The following is a description of a gene set: Catalysis of the reaction: 3'-phosphoadenosine 5'-phosphosulfate + an alcohol = adenosine 3',5'-bisphosphate + an alkyl sulfate. Mouse Gene Set: GOMF_ALCOHOL_SULFOTRANSFERASE_ACTIVITY studied in species Mus musculus, and this is the list of marker genes: Sult2b1, Sult2a8, Sult2a4, Sult2a6, Sult2a3, Sult2a5, Sult2a2, Sult2a7, Sult1c2, Sult1c1, Sult2a1